The following is a description of a gene set: species: Mus musculus Binding to a phosphatidylcholine, a glycophospholipid in which a phosphatidyl group is esterified to the hydroxyl group of choline. Mouse Gene Set: GOMF_PHOSPHATIDYLCHOLINE_BINDING, and this is the list of marker genes: Esyt1, Esyt2, Pitpnb, Rpe65, Rs1, Vdac1, Gpr119 (G-protein coupled receptor 119), Abca1, Nf1, Pcyt1a, Pitpnm2, Pltp, Serpina5, Apoa4, Rasgrp1, Chmp3, Chmp2a (NCBI Gene Id 68953), Pctp, Apoa5, Pcyt1b, Ighm, Scarb2, Apoa2, Aldob, Gpr12, Jchain, Pitpnm1, Esyt3, Pitpna, Vdac2